Given this list of marker genes TXNL4A, SRSF1, TLE4, TIMM23B, SLC7A5, SLC20A1, EFTUD2, RRP9, SNRPD3, YWHAE, VDAC1, SNRNP70, ZNF532, SUMO2, SEPHS2, SFXN1, TRAF2, SHMT1, THRA, TK1 (thymidine kinase 1), TOP1, UCN2, TFDP1, TP53, SLC25A4, TBL3, SURF6, TERT, CLPB, TYMS, ZNF330, VRK1, TARBP1, SRSF7, ZNF239 (zinc finger protein 239), UMPS, SLC6A1, SNRPD2 (NCBI Gene Id 6633), UBE2C, WDR12, HOMER1, SLC16A1, SYNGR1, UXT, TFRC, SMN1, TXN, SLC25A3, TDP1, SLC2A1, SERPINE1, WDR3, STAT5B, UAP1, RUVBL2, VARS1, THOP1, SREBF1, SRSF2, UCK2, UNC119 (NCBI Gene Id 9094), TCF3, SNRPB, TXNRD1, UCHL1, SRPK1, FEZ2, SRM, here is a description of the gene set: We report a database of genes responsive to the Myc oncogenic transcription factor. The database Myc Target Gene prioritizes candidate target genes according to experimental evidence and clusters responsive genes into functional groups. We coupled the prioritization of target genes with phylogenetic sequence comparisons to predict c-Myc target binding sites, which are in turn validated by chromatin immunoprecipitation assays. This database is essential for the understanding of the genetic regulatory networks underlying the genesis of cancers. Human Gene Set: DANG_REGULATED_BY_MYC_UP Genes up-regulated by MYC, according to the MYC Target Gene Database. studied in species Homo sapiens from publication Zeller KI, Jegga AG, Aronow BJ, O'Donnell KA, Dang CV (PMID 14519204)